Given this list of marker genes STING1, NLRC5, UBE2K, HDAC4, IFNA2, MMP12, MX1, PTPN6, IFNA7, GPR108, MYD88, IRF3, SMIM30, IFITM1, DCST1, TRIM6, SAMHD1, PTPN2, SP100, USP18, IFNB1, PTPN11, TRAF3, WNT5A, CR2, IFNAR2, PTPN1, CH25H, IFNA21, MAVS, OAS1, OASL, AZI2, RNF185, TBK1, TBKBP1, LSM14A, USP27X, TREX1 (NCBI Gene Id 82474), IFNA8, IKBKE, IFNA10, MUL1, IFITM3, EIF4E2, CACTIN, USP29, IFNA4, JAK1, IFI27, STAT2, IFIT1, STAT1, SIN3A, YTHDF2, TRIM65, IRAK1, IFIH1, IFNA5, CDC37, ZBP1, SHMT2, IFITM2, IFNA6 (interferon alpha 6), IFNA17, MIR21, RBM47, SETD2 (SET domain containing 2, histone lysine methyltransferase), TTLL12, TYK2, TRIM41, IFNA1, IFNE, ISG15 (ISG15 ubiquitin like modifier), IFNK, IFNA16, OAS2, GIGYF2, TANK, METTL3, IRF7, IFNA14, OAS3, SMPD1, CNOT7, FADD (NCBI Gene Id 8772), IFNAR1, IFNW1, YTHDF3, ADAR, SHFL, TRIM56, here is a description of the gene set: Any process that results in a change in state or activity of a cell or an organism (in terms of movement, secretion, enzyme production, gene expression, etc.) as a result of a type I interferon stimulus. Type I interferons include the interferon-alpha, beta, delta, episilon, zeta, kappa, tau, and omega gene families. Human Gene Set: GOBP_RESPONSE_TO_TYPE_I_INTERFERON species: Homo sapiens